The following is a description of a gene set: from publication Darwiche N, Ryscavage A, Perez-Lorenzo R, Wright L, Bae DS, Hennings H, Yuspa SH, Glick AB (PMID 17525749) studied in species Mus musculus Genes down-regulated during skin tumor progression: epidermis treated with the carcinogen DMBA followed by 20 weekly applications of the tumor promoter TPA, compared to the untreated skin. Chemical induction of squamous tumors in the mouse skin induces multiple benign papillomas: high-frequency terminally benign low-risk papillomas and low-frequency high-risk papillomas, the putative precursor lesions to squamous cell carcinoma (SCC). We have compared the gene expression profile of twenty different early low- and high-risk papillomas with normal skin and SCC. Unsupervised clustering of 514 differentially expressed genes (P<0.001) showed that 9/10 high-risk papillomas clustered with SCC, while 1/10 clustered with low-risk papillomas, and this correlated with keratin markers of tumor progression. Prediction analysis for microarrays (PAM) identified genes that distinguished the two papilloma classes, and a majority of these had a similar expression pattern in both high-risk papillomas and SCC. Additional classifier algorithms generated a gene list that correctly classified unknown benign tumors as low- or high-risk concordant with promotion protocol and keratin profiling. Reduced expression of immune function genes characterized the high-risk papillomas and SCC. Immunohistochemistry confirmed reduced T-cell number in high-risk papillomas, suggesting that reduced adaptive immunity defines papillomas that progress to SCC. These results demonstrate that murine premalignant lesions can be segregated into subgroups by gene expression patterns that correlate with risk for malignant conversion, and suggest a paradigm for generating diagnostic biomarkers for human premalignant lesions with unknown individual risk for malignant conversion. Human Gene Set: DARWICHE_SKIN_TUMOR_PROMOTER_DN, and this is the list of marker genes: SPC24, MORN5, ZNF787, HEXA, PMEPA1, PACSIN2, SCN1B, CP, IL17A, PDS5B, ARG1 (arginase 1), COX19 (cytochrome c oxidase assembly factor COX19), RASIP1, TPM3, NIT1, PDXDC1, SERPINB4, IL1B, GADD45GIP1, RNASE2, SMIM8, GRIP1, EBF2, C11orf58, MED17, APP, SAR1A, RNF19A, TRBV4-1, DGUOK, APOE, ZNF830, COL20A1, JAG1, VHL, ELAPOR1 (NCBI Gene Id 57535), TRPC6, RPAIN, CACYBP, CX3CR1, INAVA, YTHDF2, PEX16, MAPK8IP3, LMOD2, GDF5, MGAT1, AFF3, SOX5, HRC, MEOX2, EIF5A, TEX48, PKHD1, SLC39A13, RSPO1, PHF2 (NCBI Gene Id 79448), BCL2A1, BRF1, ABHD14B, ACAD9, RTRAF, CSPP1, CLEC3B, KRTAP6-1, CDC42EP2, NEK4, RPTN, RNF26, CAMK4 (calcium/calmodulin dependent protein kinase IV), LYAR, GID8 (NCBI Gene Id 54994), PVT1, LRRC58, KCNU1, DOK4, KLK6 (NCBI Gene Id 5653), TNFRSF25, LGALS2, FES, PUS10, UBE4B, MYCN, AMBRA1, CDS1, FAM178B, SUCLG2, HSPD1, TYRO3, HMBOX1, FAM186A, FAM217A, GALK1, CCT6B, ASNS, CALML5, SFN (NCBI Gene Id 2810), LGMN, CENPC, SFPQ, TSC22D4, MEF2C, WDR70, TXN, MSI1, TCTE1, IGHG1, UCK2, KRT2, STRAP, BRSK2, RTN4R, FAM3A, CHCHD5, CCL27, KPRP, SWAP70, ITPR1, SPAG5, PTPRJ-AS1, CSTA, C16orf90, SRF, QPRT, GSTA1, PABPC4, TLCD3B, TSSK6, SLC35B1, SARAF, TREM2, BAG6, SELENOT, POLI, PYGO2, GSTZ1, C14orf119, PDP2, FAM162A, DIP2A (NCBI Gene Id 23181), OTUD1, ACTL6B, FBRSL1, IFT20, PRRC1, MRPL19, RACGAP1, GCLM, GTF2E2, PEPD, SIGLEC5, GTF2I, NFE2L2, AKIRIN2, EEF1D, TEKTIP1, CCNI, PPP1R27, COQ8A, MT1F, CALCOCO1, SRSF1, BHLHE22, DCTN1, MYO1A, BEST1, TTC9, KRTAP5-2, BID, ACSBG1, SAMHD1, SPATA31D1, CFAP144, OGFOD2, NBN, DENR (NCBI Gene Id 8562), ANKEF1, IL36A, TMEM144, ARMC9, S100A11, ACTA1 (NCBI Gene Id 58), CHST11, SMIM11, RPL39 (ribosomal protein L39), PLA2G10, TUBA8, CALM2, ANP32A (NCBI Gene Id 8125), CEACAM21